Given this list of marker genes IGFBP4, NDUFB11, ADH5, ALDH1A2, SURF2 (NCBI Gene Id 6835), DEXI, AGTPBP1, SYPL1, RDH12, MRPS18B, DSTN, B3GALNT1, PRKCI, CETN3, MAPK14, NUP85, MCM7, SLC11A2, WBP2, SEC31A, ANXA3, HSD17B10, PPP6C, EIF4A3, TMEM184C, CLYBL (citramalyl-CoA lyase), CD48 (NCBI Gene Id 962), HSP90AB1, BET1, SUOX, DCUN1D5, PAFAH2, ATP5F1B, MEF2A, ATP6V0B, RPS9, RCN2, TIMM8B, SPIDR, ACOX1, MYB, DDX54, IFTAP, ECPAS, NEAT1, RNF141, TRIM27, EMC10, GP1BA, BDKRB2, NDUFV2, MRPL48, RPL26, AURKAIP1, EMC6, WAS, ID3, TRA2B, FERRY3, HOXC6, SMIM30 (small integral membrane protein 30), IFRD2, ABCC6, SERINC1, TARS2, FOXK2, UQCR11, MSANTD3, SDHAF4, HYPK, HDHD2, FAM149B1, ADSS2, ARHGEF12, DRG2, RNF19A, LRP1, INTS6L, SLC41A2, NSDHL, RND3, LRRC59, DDX46, NFKBIA (NFKB inhibitor alpha), NEK9, TXLNB, TOP1, SS18, PRMT5, TP73, DAP, UBALD1, HNRNPLL, GANAB, UXT, TFAP2A, ZNRF1, MLLT11, ATP1A1, UTP25, HBS1L, ATP5F1D, IRAK4, COPB1, FASTKD2, NOL7, MNAT1, ACADM, SHE, ABCD2, ERH, TCEAL9, ALG3, SNCA, MRPS23, HAUS1, FASN, PHKB, OPA3, SREBF2, SDHC, ELAVL1, LRRK2, NDUFS2, COPS6, AGFG2, DUSP16, ARFGAP3, DEGS1, REX1BD, RRAS, TXNDC5, TOP2A, AIFM1, ERO1A, MRPL57, AHCTF1, PEX11B, DGAT1, IL1RAP, ZDHHC20, S100A13, UQCRFS1, PSMC5 (NCBI Gene Id 5705), CAD, IFITM10, AKR7A2, RCVRN, MED25, POLR2H, GAS7, SLC35A4, NDUFS8, YIPF4, NPRL3, MRPL50, SERF2, GLRX3, C11orf24, GRK5, EEF1D, UBXN8, RPL38, DHCR7, MYG1, TMEM165, RAD18, PPIB, PARP1, TYROBP, FCHO1, WNT8A, PPP3CC, ACKR3, MESD, RPS2 (ribosomal protein S2), PAPSS1, TIMM8A, PPP1CC, EML3, C1GALT1C1, APPBP2, HSP90B1, DDB1, PKP2 (NCBI Gene Id 93271), NOTCH2, GATD3, CD70, MAP3K8, ATOSB, CD320, TMEM205, ST3GAL5, RPP14, SRP9, SNRNP25, AGPAT3, PKM, COTL1, here is a description of the gene set: mouse primary BMDCs were stimulated with tlr ligands and gene expression changes were profiled on Affymetrix arrays from publication Amit I, Garber M, Chevrier N, Leite AP, Donner Y, Eisenhaure T, Guttman M, Grenier JK, Li W, Zuk O, Schubert LA, Birditt B, Shay T, Goren A, Zhang X, Smith Z, Deering R, McDonald RC, Cabili M, Bernstein BE, Rinn JL, Meissner A, Root DE, Hacohen N, Regev A (PMID 19729616) Human Gene Set: GSE17721_POLYIC_VS_PAM3CSK4_16H_BMDC_DN studied in species Homo sapiens Genes down-regulated in comparison of dendritic cells (DC) stimulated with poly(I:C) (TLR3 agonist) at 16 h versus DC cells stimulated with Pam3Csk4 (TLR1/2 agonist) at 16 h.